The following is a description of a gene set: from publication Toker A, Engelbert D, Garg G, Polansky JK, Floess S, Miyao T, Baron U, Düber S, Geffers R, Giehr P, Schallenberg S, Kretschmer K, Olek S, Walter J, Weiss S, Hori S, Hamann A, Huehn J (PMID 23420886) Human Gene Set: GSE42021_TREG_PLN_VS_TREG_PRECURSORS_THYMUS_DN We investigated at which stage of maturation commitment to a stable Foxp3-expressing phenotype takes place. We assessed stability of Foxp3 expression in thymic Foxp3+ Treg subsets of different maturity, defined by CD24 expression. Next we compared gene expression profiles of Foxp3+ Treg subsets (+) of different maturity (24lo, 24int, 24hi) and could identify a set of genes that were specifically up or downregulated in Foxp3+ Tregs, but not in Foxp3- conventional T cells, in a maturation-dependent manner. Genes down-regulated in T reg from: peripheral lymph nodes versus thymic precursors. species: Homo sapiens, and this is the list of marker genes: NRP1, BTN3A1, TLK2, CASP8, EHD4, UBE2L6, GBP1, NAPA, SQOR, OAS3, DCP1A, RGS11, DUSP22, ID4, PARP12, TDRD7, GATA3, SP110, CASP7, TLR3, TNFSF10 (NCBI Gene Id 8743), IFI44, SAMD9, TRANK1, IFITM1, OR1A2, IFIT2, GTPBP2, BMP10, NLE1, OPTN, HLA-F, IFIT3, ANKFY1, LY6E, LPAR4, EXT1, TCIRG1, OSMR, RNF114, TMEM140, OAS1, JADE2, BCL2L13, PSMB9, TLE3, PCDHGA11, SCARB2, SLC15A3, IFI44L (interferon induced protein 44 like), OAS2, B2M, TRIM25, TENT5A, TRIM22, NMI, MX1, CHMP5 (NCBI Gene Id 51612), SP100, SPATS2L, LGALS3BP, CFB, SP140L, FMR1, IFI27, SAMHD1, GTF2A1, CYTH1, SHFL, CDC42EP4, SHOX2, C1S, PRKD2, PML, MX2, GNA14, NKX3-1, ISG20, SLC25A28, VAX2, TRIM38, RBCK1 (RANBP2-type and C3HC4-type zinc finger containing 1), PSMB10, TNNC2, XAF1, ZC3HAV1, HEG1, RSAD2, DDX60, CD47, FOXF1, TAP2, ELF1, EPPK1, LAP3, HLA-E, TRIM21, TMEM62, SOCS1, WDR91, APOL1, TRIM5, LYPD3, STAT3, CREM, BLZF1, TRIM26, IL15, ETS2, PSME1, OGFR, REC8, RBBP6, SCNN1G, PLSCR4, HLA-C, RNF19B, EIF2AK2, PARP4, IFITM3, WBP4, IRF9 (NCBI Gene Id 10379), PLSCR1, PHF11, TAP1, RASGRP3, ZDHHC8BP, TYMP, SCAMP1, KLHL11, CD3E (NCBI Gene Id 916), MSRB1, IFIT1, CALCOCO2, BST2, ISG15, ZNF107, APOL2, LAMP3, BTN3A3, SERPINA3, NFE2L3, IGFLR1, IFITM2, MAFF, HERC6, TAPBP, IFI30, HLA-J, ADGRE1, AQP8, IL22RA1, IRF1, ZFX, IL15RA, TREX1, RIGI (RNA sensor RIG-I), BMPR2, SMARCA5, PSME2, IFI35, STAT2, USP18, ST3GAL4, THEMIS2, PLXNB3, LARS2, IFIT5, PSMB8, DECR2, IFIH1, HERC5 (NCBI Gene Id 51191), TRIM14, MYD88, STAT1, LMO2, OASL, RNF31 (NCBI Gene Id 80191), CYP4F11 (cytochrome P450 family 4 subfamily F member 11), IL12A (interleukin 12A), PARVA, WASL (NCBI Gene Id 8976), ZCCHC2, DSP, DEDD, IFI6, FAS, SNRPF (small nuclear ribonucleoprotein polypeptide F), HLA-G, TRAFD1, ADAR, HLA-A, GTPBP1, HLA-B, IRF7, IFI16, OR2H1, APOL6, CD96, SERPINB9